Given this list of marker genes MAP2K2, RAF1, KRAS, RET, MAP2K1 (mitogen-activated protein kinase kinase 1), MAPK3, NRAS, BRAF, MAPK1, HRAS, ARAF, here is a description of the gene set: studied in species Homo sapiens Pathway Definition from KEGG: RET* -> RAS -> RAF -> MEK -> ERK RET fusion kinase to RAS-ERK signaling pathway. Pathway ID: N00008. Pathway type: Variant. Pathway class: nt06266 Non-small cell lung cancer. Human Gene Set: KEGG_MEDICUS_VARIANT_RET_FUSION_KINASE_TO_RAS_ERK_SIGNALING_PATHWAY